Given this list of marker genes ZNF503, TMEM163, SLC2A13, GTF3C4, TUT7, here is a description of the gene set: from publication Chen Y, Wang X (PMID 31504780) Genes predicted to be targets of miRBase v22 microRNA hsa-let-7e-3p in miRDB v6.0 with MirTarget v4 prediction scores > 80 (high confidence targets). studied in species Homo sapiens Human Gene Set: LET_7E_3P